Given this list of marker genes DAB1, GTF2H5, ITPR1, PNPT1, AARS1, CARS1, PEX10, TXN2, CAMLG, ERCC2 (NCBI Gene Id 7269), MPLKIP, EMC1, BTD, RNF113A, CARS2, KIF1A, GTF2E2, TARS1, TBC1D24, ERCC3, FMR1, here is a description of the gene set: Human Gene Set: HP_DIFFUSE_CEREBELLAR_ATROPHY Diffuse cerebellar atrophy species: Homo sapiens Diffuse unlocalised atrophy affecting the cerebellum.